Given this list of marker genes CD69, JAK3, RC3H2, FOXP3, ZBTB7B, LOXL3, LGALS1, ZC3H12A, STAT5A, RC3H1, SMAD7, IL27RA, TNFSF18, ASCL2, TBX21 (NCBI Gene Id 30009), IL2, here is a description of the gene set: Any process that stops, prevents or reduces the frequency, rate or extent of T-helper 17 type immune response. studied in species Homo sapiens Human Gene Set: GOBP_NEGATIVE_REGULATION_OF_T_HELPER_17_TYPE_IMMUNE_RESPONSE